Given this list of marker genes KLK13, ST20, LIMS1, RHBDF1, STX3, BNIP3L, ZBED6, BCL2A1, STX6, ADD2 (NCBI Gene Id 130935), LINC02210, TNRC6B, SH3BP5, KREMEN1, CERT1, KCNK5, RGL4 (NCBI Gene Id 266747), ERC2-IT1, ARHGAP27, HCAR3, HDDC3, SRGAP3, LGMN, CNEP1R1, TRIO, NTSR1, IL6ST-DT, DDX60L, SMC1B, LINC02877, ACVR1B, CARD6, IFI27L1, RALA (RAS like proto-oncogene A), PDPN, HSPBAP1, GLIS3 (NCBI Gene Id 648268), TINF2, PHC2, ATP8B4, UNC50, ADNP, LEPROT, TMEM38B, ZNF230, SAT2, SPTLC2, FCGR1A, B3GNT2, LAT2 (NCBI Gene Id 7462), NDST1, JAKMIP2, IL6-AS1, TCF7L2, STX1A, DIAPH1, DGKH, HAS1, LPCAT1, AHRR, SH3BGRL, MROH6 (maestro heat like repeat family member 6), UBE2E3, NPC1, DAB2 (NCBI Gene Id 1601), FKBP15, CPM, C12orf54, EVI2A (ecotropic viral integration site 2A), GSTO1, MET, BTG3, IL24, MFAP3, ACCS, OR3A2, NDRG1 (NCBI Gene Id 7998), IRAK1, SLC2A3, CLEC5A, PLSCR2, YIPF6, TRIM13, CLEC4E, DBIL5P, NXT2, DCBLD1, ATXN7, FYN, OR5L2, IRS2, SPATS2, PPBP, MCHR1, PRLR, RTN4RL2, ABHD14A (abhydrolase domain containing 14A), CCL20, NSMAF (NCBI Gene Id 8439), PJA1, TLR6, LTB4R, RXFP3, RASAL3, SLC11A1, EREG, SLC31A2, BLOC1S1, LTBP1, FHIP1B, BCAT1, VAV3, RRAGD, GOLGA8IP, TMPO, DCAF12 (NCBI Gene Id 25853), ATP9B, CXCL8, CHMP5, ADM, ASAH1, TCL6, FTHL17, HTRA1, SLTM, VPS37A, SLC22A15, ARAP3, MARCO, PID1, ARL5B, ZNF652, ING2, C10orf55, METTL9, SLK, C3orf52, ZNF16, NFE2L2, DEPDC1B, TMLHE, RUNX3, PNPLA8, LINC00922, RGP1, ELOVL6, ALOX5AP, MYL12A, FBXL5, GPR68, PNPLA7, BHMT2, RP1, D2HGDH, DNAL4, HM13, PDCD6IP, IGLV1-44, CAB39L, CCDC50, LINC01426, BRI3, USF3, TAF8, TSC22D1, MS4A15, TXLNB, RBFOX1, PPIF, ARID2, MCTP1, PNP, ZFAND6, CALHM3, IL16, EAF2, SH3GLB1 (NCBI Gene Id 51100), LYSET, SIRPB2, TRPS1, RET, LGALS8, HBBP1 (hemoglobin subunit beta pseudogene 1), NSF, PINK1, ARHGEF3, PLAUR, BST1, PROCR, SNX9, PPP1R2, LRRC8D, CCL7, here is a description of the gene set: Human Gene Set: GSE2770_IL12_ACT_VS_ACT_CD4_TCELL_2H_UP Th1 and Th2 cells arise from a common precursor cell in response to triggering through the TCR and cytokine receptors for IL-12 or IL-4. This leads to activation of complex signaling pathways, which are not known in detail. Disturbances in the balance between type 1 and type 2 responses can lead to certain immune-mediated diseases. Thus, it is important to understand how Th1 and Th2 cells are generated. To clarify the mechanisms as to how IL-12 and IL-4 induce Th1 and Th2 differentiation and how TGF-beta can inhibit this process, we have used oligonucleotide arrays to examine the early polarization of Th1 and Th2 cells in the presence and absence of TGF-beta after 0, 2, 6 and 48 hours of polarization. from publication Lund R, Aittokallio T, Nevalainen O, Lahesmaa R (PMID 14607935) species: Homo sapiens Genes up-regulated in CD4 T cells activated by anti-CD3 and anti-CD28: IL-12 (2h) versus untreated (2h).